Given this list of marker genes Add1, Casp8, Plec, Sptan1, Gas2, Gsn, Casp7, Casp3, Sorbs2, Vim, Casp6, Mapt, here is a description of the gene set: Mouse Gene Set: REACTOME_CASPASE_MEDIATED_CLEAVAGE_OF_CYTOSKELETAL_PROTEINS Caspase-mediated cleavage of cytoskeletal proteins species: Mus musculus